Given this list of marker genes DVL1, DVL2, FGF8, EPB41L5, NOG, VANGL2 (VANGL planar cell polarity protein 2), here is a description of the gene set: Human Gene Set: GOBP_NEURAL_PLATE_MORPHOGENESIS species: Homo sapiens The process in which the anatomical structures of the neural plate are generated and organized. The neural plate is a specialized region of columnar epithelial cells in the dorsal ectoderm that will give rise to nervous system tissue.